Given this list of marker genes Rps27a, S100b, Ppp2r1b, Vrk3, Map2k7, Mapk8, Tab3, Mapk7 (NCBI Gene Id 23939), Jun, Map2k4, Irak1, Nfkb1, Tab1, Rela, Lrrc14, Rps6ka5, Map2k6, Ubb, Tirap, Ecsit, Mapk14, Hmgb1, Dusp7, Casp8, Dusp6, Mapk3, Mapk11, Mapk9 (NCBI Gene Id 26420), Nlrc5, Nlrx1, Tab2, Ikbkb, Ppp2r5d (protein phosphatase 2, regulatory subunit B', delta), Map2k3, Tifa, Nkiras1, Peli2, Ube2v1, Nfkb2, Nfkbib, Ube2n, Nfkbia, Cul1, Ager, Fos, Map3k8, here is a description of the gene set: Reactome Pathway: Toll Like Receptor 2 (TLR2) Cascade studied in species Mus musculus electronically inferred by orthology from the curated human pathway This event has been computationally inferred from an event that has been demonstrated in another species.<p>The inference is based on the homology mapping from PANTHER. Briefly, reactions for which all involved PhysicalEntities (in input, output and catalyst) have a mapped orthologue/paralogue (for complexes at least 75% of components must have a mapping) are inferred to the other species. part of: Toll-like Receptor Cascades